Given this list of marker genes NOG, AGTR2 (angiotensin II receptor type 2), PPP3CA, PAX2, RET, here is a description of the gene set: Human Gene Set: GOBP_POSITIVE_REGULATION_OF_GLOMERULUS_DEVELOPMENT studied in species Homo sapiens Any process that increases the rate, frequency or extent of glomerulus development, the progression of the glomerulus over time from its initial formation until its mature state. The glomerulus is a capillary tuft surrounded by Bowman's capsule in nephrons of the vertebrate kidney.